Given this list of marker genes MIR145, MYLK, COL3A1, PROX1, MIR143, EFEMP2, here is a description of the gene set: Human Gene Set: GOBP_AORTA_SMOOTH_MUSCLE_TISSUE_MORPHOGENESIS The process in which the structure of the smooth muscle tissue surrounding the aorta is generated and organized. An aorta is an artery that carries blood from the heart to other parts of the body. species: Homo sapiens